Given this list of marker genes Igfbp1, Jun (jun proto-oncogene), Gap43, Cers2, Anxa1, Cspg5, Mstn, Lamb2, Serpina10, mt-Cytb (mitochondrially encoded cytochrome b), Apoa5, Adm, Cxcl12, Xylt1, Nefh, Ace, Yap1, Ptpn12, Enpp1, Egfr, Wnt10b, Jak2, Hgf (hepatocyte growth factor), Snhg15, Apoa1, Myf6, Flna, Ascl3, Gfer, Nrep, Apoa2, Cpb2 (carboxypeptidase B2, NCBI Gene Id 93820), Ccnd1, Mtpn, Lif, Mymx, Bex1, F7, Lgr6, Thy1, Cxcl5, Ppard, Ninj1, Aurka, Fbxw10, Tgfb1, Pum2, Nrg1, Ccn3, Plg, Cdkn1b, Cebpb, Rtn4, Rtn4r, Cdkn1a, Fgf10, Myod1, Ptn, Fas, Cd9, Kremen1, Postn, Igsf10, Prrx1, Mcub, Gfap, Angpt2, Csnk2a1 (casein kinase 2, alpha 1 polypeptide), Dag1 (NCBI Gene Id 13138), Gnat1 (G protein subunit alpha transducin 1), Notch1, Rtn4rl2, Lrig2, Diaph2 (NCBI Gene Id 54004), Tnr, Mapk8ip3, Mmp2, Wnt7a, Bdnf, Ulk1, Dusp10, Ihh, Apoe, Cldn1, Atic, Apoh, Upf2, Sox2, Dysf, Apoa4, Il10, Ndel1, Map4k4, Sgca, Rtca, Tspo, Cd81, Eppk1, Tmem182, Gata4, Stk24, Ugt1a1, Pax7, Rgma, Capn3, 9630013A20Rik, Cpq, Pkm, Mustn1, Ctnna1, Gja1, Med1, Akirin1, Lrp1, Matn2, Cntf, Nanog, Igf2r, Gli3, Elavl4, Ifrd1, Reg1, Hmox1, Ptgfrn, Fkbp1b, Rgn, Epha4, Gata1, Dmd, D130043K22Rik, Map2k2, Cflar (CASP8 and FADD-like apoptosis regulator), Ptprs, Slc7a5, Chl1, Fzd7, Vtn, Xirp1, Igf1, Ptch1, Ptpn3, Neo1, Selenon, Adh1, Cad, Erbb4, Braf, Dicer1, Hopx, Gstp1, Adam15, Fpgs, Bcl9, Map1b (NCBI Gene Id 268696), Tarbp2, Folr1, Spaar, Sulf2, Ninj2, Bin3, Lcp1, Baat, Bcl2, Serpine1, Ucp2, Mir675, Tyms, Synb, Gnat2, Plau, Nr0b2, Gm34220, Pcna, Nfib, Tnc, Vps54, Ccna2, Mymk, Inpp5f, Gpx1, Ntrk3, Gjd4, Fzd9, Cdk1, Col6a1, Ptprf, Ccl2, Il6, Adam17, Igf1r, Mir489, Hfe, Grn, Large1, Pten, Mdk, Dhfr, Ezh1, Myoz1, Nefl, Klf4, B4galnt2, Gas6, P2rx5, Ezh2, Hdgfl2, Nfix, Fkrp, Pdx1, Mtr (NCBI Gene Id 99131), Wnt1, Pnpt1, Scarf1, Lifr (NCBI Gene Id 319661), Ggt1, Omg, Klf5, Diaph1, Mir682, Axl, Gli1, Pfkfb1 (6-phosphofructo-2-kinase/fructose-2,6-biphosphatase 1), Tnf, Mag, Bak1, Nnmt, Cpt1a (NCBI Gene Id 225890), Ptpru, Itpr1, Kpna1, Anxa3, Rpl10, Rtn4rl1, Sox15, Apod, Phb1, Map2k1, here is a description of the gene set: The regrowth of a lost or destroyed body part, such as an organ or tissue. This process may occur via renewal, repair, and/or growth alone (i.e. increase in size or mass). species: Mus musculus Mouse Gene Set: GOBP_REGENERATION